The following is a description of a gene set: Genes having at least one occurrence of the motif NGATAAGNMNN in the regions spanning 4 kb centered on their transcription starting sites. This matches the GATA1 transcription factor binding site V$GATA_C (v7.4 TRANSFAC). Human Gene Set: GATA_C species: Homo sapiens, and this is the list of marker genes: HPSE2, MACIR, HOXB1, ZIC4, NOCT, MED26, C12orf42, GRIK3, PRDX2, SLC46A1, AK9, ZBTB20, SYNDIG1, FGF14, RHAG, SRSF2, SPTSSB, MXD1, ISL1, MYCT1, PRSS3, HOXD1, LRIG3, CHST6, ETV1, TACC1, ONECUT2, ALMS1, GNB3, YBX1 (Y-box binding protein 1), HOXB4, ZNF219, BDNF, ANGPT2, FBXW11, HS3ST4, ELAVL4, ALPK2, MOGAT2, P2RY12, SYT7, MED27, HS6ST3, ZBTB7B, LINC03122, GFI1B, ACVR1, DMTN, PTCHD4, USP15, PPM1E, FOXO4, MYRF, BLVRB, CNTLN, UBE3A, CXCL13, UBE2F, CDH7, PNLIPRP1, CDH9, HOXC6, TNFRSF19, BTRC, MBD1 (NCBI Gene Id 4152), KRT73, NRXN3, NECTIN2, APMAP, PRSS1, GATA6, ZNF385B (zinc finger protein 385B), PLEKHG6, ECHDC2, RPAP2, SLC6A5, IL7, RARB, HOXA7, PHOX2A, GATA1, RGN, LGI1, LUC7L3, EYA1 (EYA transcriptional coactivator and phosphatase 1), CDIN1, MASP1, COLQ, DMD, TMEM179, PPL, FCGBP, CTSE, PREX1, IL22, TEK, SATB1 (SATB homeobox 1), TSKU, GLMN, MAP4K5, NDUFA4L2, FAM91A1, SRGAP1, SLITRK2, LCAT, UPK1B, PHOSPHO1, FRMD5, ACKR1 (atypical chemokine receptor 1 (Duffy blood group)), PLS1, PCYT2, KRT20, PALS1, RBPMS, ARF6, ALKBH3, WDR82, PKLR, FHL3, CSF2, SLC34A3, LINC00670, HNF1A, DSPP, PPOX, SLC18A1, SLC35A2, PKHD1L1, GP2, CD34, NAA80, DCX, LMO2, LITAF, SIX1, HOXC4, PAX2, SLC4A1, CALHM5, CCL27, ZIC1, MTA2, AMOT, APOOL, EDN1, HOXA3, RHCE, ZSWIM8, KLF12, JUN, NFRKB, PSMA8, FBXL7, MSR1, CLDN10, ARAP2, ZHX3, KCTD6, RBMS3, PRKAG1, LYL1, C1orf21, MAP2K5, MID1, LIFR, HEMGN, CTDSPL2, STON2, CITED4, GUCA2A (NCBI Gene Id 2980), PCDH11Y, PLAG1, FABP2, BMP6, GATM, GDPD1, PPM1D, POLR3D, SPTBN4, RHD, CPLX2, ZFPM1, RGS13, CTNND1, GSE1, GBX2, S100PBP, EDA, MITF, KRT71, GDF3, AMBN, SOX10, H3-3A, EN1, PIGV, PDZD2, NHLH2, MECOM, ZNF711, FOSL2, IGFBP5, SUPT16H, KCNK3 (potassium two pore domain channel subfamily K member 3), AQP2, SNW1, KLHDC3, SCUBE3, ATP2A3, NR5A2, HBEGF, AIF1L, DCN, MYOG, MYO1C, CSF3, GABBR1, BPGM, FTH1, TOB1, PLA2G1B, PPT2, B3GALT2, PRSS22, WNT11, CPT1C, TPM3, ADGRF5, RORB, RPL13A, HYAL3, SLC26A7, PLCB3, PCDH11X, CNN1, TFEC, IL1RL1 (NCBI Gene Id 9173), TAFA1, PRR18, MEA1, NOL4L, DDX17, ADORA3, SERTAD4, ESRRG, ANKS1B, SNTG1, DUSP6, CFAP161, KLF14, PTF1A, INHA, CHCHD7 (coiled-coil-helix-coiled-coil-helix domain containing 7), CAST, GABPB2, SLCO1C1, HEPH, RSPO2, LINC01555, RUNX1T1, VPS18 (NCBI Gene Id 57617), MATN1, SOX5, CCSER2, PHEX, BCL9, ITGA5, UBE2H